Given this list of marker genes EIF3I, EIF4G1, EIF4B, EIF4H, EIF3F, BZW1, EIF4A2, EIF3H, EIF3C, EIF3G (NCBI Gene Id 9606), EIF4G2, EIF5A, EIF4EBP1, EIF6, EIF3D, HSPB1, EIF4A1, EIF3E, EIF4EBP2 (NCBI Gene Id 1979), EIF1, here is a description of the gene set: Human Gene Set: MODULE_81 studied in species Homo sapiens Genes in the cancer module 81.